Given this list of marker genes CDK1, MSH6, CENPS, CDKN1B, MCM2, SUV39H2, RPA3, SMC2, ERCC6L, HDAC2, PTTG1 (NCBI Gene Id 9232), TDP1, RFC3, RFC4, RMI1, MND1, MSH2, RFC2, ZWINT, SMC3, CHEK1, RACGAP1, CENPM, GMNN, PCNA, GINS2, BRCA1, MCM5, RAD21, FANCD2, MCM7, PRIM1, ATR, CDC25A, EXO1, MAD2L1, BIRC5, here is a description of the gene set: studied in species Homo sapiens Vaccination with attenuated live varicella zoster virus (VZV) can prevent zoster reactivation, but protection is incomplete especially in an older population. To decipher the molecular mechanisms underlying variable vaccine responses, T- and B-cell responses to VZV vaccination were examined in individuals of different ages including identical twin pairs. Contrary to the induction of VZV-specific antibodies, antigen-specific T cell responses were significantly influenced by inherited factors. Diminished generation of long-lived memory T cells in older individuals was mainly caused by increased T cell loss after the peak response while the expansion of antigen-specific T cells was not affected by age. Gene expression in activated CD4 T cells at the time of the peak response identified gene modules related to cell cycle regulation and DNA repair that correlated with the contraction phase of the T cell response and consequently the generation of long-lived memory cells. These data identify cell cycle regulatory mechanisms as targets to reduce T cell attrition in a vaccine response and to improve the generation of antigen-specific T cell memory, in particular in an older population. Genes negatively correlated with peak T cell response 28d in peripheral blood mononuclear cell in seniors (50-75) after exposure to Zostavax, time point 14D. Comment: negative correlation coefficients between gene expression level at day 14 after vaccination and peak to day 28 T cell responses Human Gene Set: QI_PBMC_ZOSTAVAX_AGE_50_75YO_CORRELATED_WITH_28D_PEAK_T_CELL_RESPONSE_14DY_NEGATIVE from publication Qi Q, Cavanagh MM, Le Saux S, Wagar LE, Mackey S, Hu J, Maecker H, Swan GE, Davis MM, Dekker CL, Tian L, Weyand CM, Goronzy JJ (PMID 27764254)